The following is a description of a gene set: studied in species Mus musculus Mouse Gene Set: GOBP_REGULATION_OF_AUTOPHAGOSOME_ASSEMBLY Any process that modulates the frequency, rate or extent of autophagosome assembly., and this is the list of marker genes: Rab3gap1, Ulk1, Snx30, Pip4k2a, Smcr8, Mtmr3, Snx4, Rnf186, Snx7, Ephb2, Scfd1, Ralb, Efnb1, Ehmt2, Rab3gap2, Fez1, Rnf5, Rab1b, Pip4k2b, Mtm1, Pikfyve, Trim32, Chek2, C9orf72, Wdr45, Tbc1d12, Snx18, Fez2, Lrrk2, Wipi1, Nupr1, Ift88, Pink1, Elapor1, Atg2a, Tmem39a, Sec22b, Sh3glb1, Lrsam1, Ift20, Phf23, Mtor, Becn1, Ubqln2 (NCBI Gene Id 54609), Moap1, Pip4k2c, Tbc1d14